Given this list of marker genes Itga4, Icam1, Krit1, Tnfaip3, Gata3, Col4a3, Fasl, Mapk7, Gata2, Gas6 (growth arrest specific 6), Gper1, Itgb3, Tert, Il13, Scg2, Serpine1, Ramp2, Angpt1, Ptpn1, Map3k5, Fgf21, Cd248, Fgg, Tek, Rgcc, Il10, Pdcd4, Pak4, Sema5a, Thbs1, Bmpr2, Akr1c18, Ngfr, Xbp1, Angptl4, Braf, Tnip2, Mir124a-1hg, H2-M3, Kdr, Hipk1, Fga, Plcg1, Pdpk1, Abl2, Ccl12, Prkci (protein kinase C, iota), Ager, Fgb, Ano6, Nfe2l2, Ndnf, Id1, Cd160, Cd40, Abl1, Cdh5, Foxo3, Col18a1, Tgfb1, Cd40lg, Tnf, Ecscr, Bmp4, Il4, here is a description of the gene set: Any apoptotic process in an endothelial cell. An endothelial cell comprises the outermost layer or lining of anatomical structures and can be squamous or cuboidal. Mouse Gene Set: GOBP_ENDOTHELIAL_CELL_APOPTOTIC_PROCESS studied in species Mus musculus